Given this list of marker genes Ap1s3, Ap4m1 (adaptor-related protein complex AP-4, mu 1), Sec31b, Ap5b1, Copg2, Copb2, Sec23b, Epn3, Necap2, Pdcd6, Baiap2l2, Scn10a, Sec23a, Vps16, Igf2r, Clta, Ap2s1, Picalm, Cideb, Ston2, Chmp2a, Tmed3 (NCBI Gene Id 66111), Ap3b1, Ap2a1, Klhl12, Ap1s1, Dab2, Tbc1d5, Sar1a, Sec31a, Necap1 (NCBI Gene Id 67602), Aftph, Sgip1, Cltb, Ap4s1, Scyl1, Vps11, Ap2b1, Eps15l1, Tepsin, Chmp1b, Ap1g1, Clint1, Sec24b, Ap3d1, Sec24a (SEC24 homolog A, COPII coat complex component), Ap2a2, Cltc, Copg1, Sar1b, Ap5s1, Cope, Dnm1, Copz2, Arcn1, Enthd1, Ap3s1, Ap2m1, Ap1s2, Lrrn3, Eps15, Vps39 (NCBI Gene Id 269338), Sec13, Sec24c, Arl6, Dipk2a (NCBI Gene Id 68861), Ap3m2, Kcnq5, Ston1 (NCBI Gene Id 98083), Synj1, Pef1, Ap3b2, Ap4e1, Epn1, Chmp4b, Trf (transferrin), Ap1b1, Vps33a, Ap1m2, Vps41, Epn2, Sec24d, Sclt1, Copz1, Synrg, Ap3m1, Clba1, Ap5z1, Ap1m1, Snap91, Aak1, Ap5m1 (adaptor-related protein complex 5, mu 1 subunit), Copb1, Ap3s2, Ap1g2, Vps18, Btbd8, Ap4b1, Slc18a3, Copa, here is a description of the gene set: species: Mus musculus Mouse Gene Set: GOCC_MEMBRANE_COAT Any of several different proteinaceous coats that can associate with membranes. Membrane coats include those formed by clathrin plus an adaptor complex, the COPI and COPII complexes, and possibly others. They are found associated with membranes on many vesicles as well as other membrane features such as pits and perhaps tubules.